Given this list of marker genes GPD1, MMP1, ZMYM2, CASP12, ARHGEF11, EMILIN1, DHRS7C, GPR173, TRIM21, PLCD4, GBP2, CAB39, AGT, STYXL2, AKNA, CAMK1G, CYP2J2, GLMP, GGNBP1, KIF1C, C20orf96, SLC25A18, GPSM3, PTGDS, TMEM248, ECM2, PINLYP, SERPINB8, VWA5A, GAL3ST4, SARDH, CP, MASP1 (NCBI Gene Id 5648), ZSCAN2, C1orf54, CYP4F8, TREX1, AKT3, IQUB, RDH5, DAPK3, MLC1, MRPS21, FGF1 (NCBI Gene Id 29961), FABP7, TNS2, TGM5, TMEM176A, BTBD17, TIMP4, FGD4, KCNIP3, AMPD3, PLPPR2, KIAA0232, PIPOX, ECRG4, DDR1, GLRX, SEC16B, here is a description of the gene set: species: Mus musculus Genes with low-CpG-density promoters (LCP) bearing histone H3 trimethylation mark at K4 (H3K4me3) in neural progenitor cells (NPC). from publication Mikkelsen TS, Ku M, Jaffe DB, Issac B, Lieberman E, Giannoukos G, Alvarez P, Brockman W, Kim TK, Koche RP, Lee W, Mendenhall E, O'Donovan A, Presser A, Russ C, Xie X, Meissner A, Wernig M, Jaenisch R, Nusbaum C, Lander ES, Bernstein BE (PMID 17603471) We report the application of single-molecule-based sequencing technology for high-throughput profiling of histone modifications in mammalian cells. By obtaining over four billion bases of sequence from chromatin immunoprecipitated DNA, we generated genome-wide chromatin-state maps of mouse embryonic stem cells, neural progenitor cells and embryonic fibroblasts. We find that lysine 4 and lysine 27 trimethylation effectively discriminates genes that are expressed, poised for expression, or stably repressed, and therefore reflect cell state and lineage potential. Lysine 36 trimethylation marks primary coding and non-coding transcripts, facilitating gene annotation. Trimethylation of lysine 9 and lysine 20 is detected at satellite, telomeric and active long-terminal repeats, and can spread into proximal unique sequences. Lysine 4 and lysine 9 trimethylation marks imprinting control regions. Finally, we show that chromatin state can be read in an allele-specific manner by using single nucleotide polymorphisms. This study provides a framework for the application of comprehensive chromatin profiling towards characterization of diverse mammalian cell populations. Human Gene Set: MIKKELSEN_NPC_LCP_WITH_H3K4ME3